Given this list of marker genes SORT1, C1QL1, ADGRB3, C1QL2, PLXNA4, TMEM240, PLXNC1, GRN, ITGB1, here is a description of the gene set: Human Gene Set: GOCC_CEREBELLAR_CLIMBING_FIBER_TO_PURKINJE_CELL_SYNAPSE studied in species Homo sapiens A synapse of a climbing fiber onto the dendrites of a Purkinje cell in cerebellum. The climbing fiber originates from the inferior olivary nucleus of the medulla oblongata.